The following is a description of a gene set: The directed movement of L-proline across a membrane. Human Gene Set: GOBP_L_PROLINE_TRANSMEMBRANE_TRANSPORT species: Homo sapiens, and this is the list of marker genes: SLC38A2, ACE2, SLC6A20 (NCBI Gene Id 56960), CLTRN, SLC36A4